Given this list of marker genes ZRANB1, USP17L6P, OTUD7A, USP17L24, USP28, OTUD7B, USP9X, TNFAIP3, here is a description of the gene set: studied in species Homo sapiens The removal of one or more ubiquitin groups from a protein as part of a process of ubiquitin-dependent protein catabolism. Human Gene Set: GOBP_PROTEIN_DEUBIQUITINATION_INVOLVED_IN_UBIQUITIN_DEPENDENT_PROTEIN_CATABOLIC_PROCESS